Given this list of marker genes BHLHE40, SPPL2A, SNX25, NEUROG2, PTPRE, HOXB3, SP4, POU3F2, UBB, FAM120A, SF3B1, TPD52, ADGRL3, PCDH9, MIDEAS, EIF4A2, FBXO21, SRSF5, ATP6V1A, PLEKHA5, VCPIP1, GABRB3, PANK3, H3-3B, SUV39H2, B3GNT5, SLC30A8, EDNRB, GAPVD1, SH3D19, ARID1B, VEZT, OTX2, DDX3Y, ACACA, MAF, GPHN, FCHO2, PTP4A2, WDTC1, SNAP91, CSMD3, CYFIP2, PTPN3 (protein tyrosine phosphatase non-receptor type 3), SENP6, FOXG1, USP15, PCSK6, GGNBP2, SALL3, EPC2, SPTY2D1, PHF14, BMP2 (NCBI Gene Id 650), KANSL2, LRCH2, ACBD3, MEIS2, PPARA, UNC5D, TBL1X, DMRT2, KHDRBS2, STRN, ARL4A, FMN2, ZCCHC24, GAD1, FKBP4, FXR1, PCF11, GOLPH3, HNRNPH1, VPS8 (NCBI Gene Id 23355), UBR3, CHD6, CSNK1D, KIF4A, ATP10A, MATR3, MAPRE1, ZBTB18, ADCY1, MTMR6, ANKRD12, DCAF7, PPARGC1A, H3-5, ATP6V1B2, ST6GALNAC3, DLX1, RNF6, KLHL24, TNRC6B, GID4, SON, AMMECR1, IL13RA1, CAND1, KLHDC10, PPP2R5E, SBF2, VEZF1, MAGI1, METAP1, HNRNPA2B1, ZIC3, GPC4, NFIX, GABPA, PPP1R12A, GABRA2, RAB14, PARP1, UBQLN1, GPRASP2, MAK, SMAD4, FBXO33 (F-box protein 33), LUC7L3, TBR1, R3HCC1L, HOXA13, SRSF2, FAM117A, SOX3, SAMD8, FOXP1, PHACTR2, SPRY1, SPCS2, CPEB2, ARK2N, PPP3R1 (NCBI Gene Id 5534), LCA5, TOB1, ABR, RNF13, NRP2, DAZAP1, KCTD8, CREM, IMMT, NFAT5, ZFP36L1, ZNF319, ZFPM2, PPA2, KHDRBS3, ASF1A, TEAD1, NPY2R, USP33, SLC35A1, KMT2E, PHF20L1 (NCBI Gene Id 84165), CBLN2, PCBP1, RAP1B, ACVR1, RTL4, B4GALT5, SIPA1L2, PDS5A, LATS1, MRFAP1, NRIP1, CYRIA, TTC7B (NCBI Gene Id 145567), EHD3 (NCBI Gene Id 30845), LRATD2, FOXA1, PLPPR5, ADD3, CGGBP1, EIF3J, DNAJB6 (NCBI Gene Id 9186), MYT1 (myelin transcription factor 1), CDK19, SOX11, RAB7A, SPOP, DDX3X, USP1, RBM39, FZD4 (frizzled class receptor 4), SSX2IP, IRS2, BTBD3, TMEM243, ATP2C1, NFYB, PPP2R2C, LIFR, CCNT2, PAK5, RNF11, WNT3, FBXL3 (NCBI Gene Id 26224), RNF138, NHSL2, NUMB, CADM2, HORMAD1, PPP5C, CMSS1, MED13, DACH1, CREB5, UBE2V2, NUP153, GARRE1, YY1, DAAM1, TNFSF11, TLL1, HBEGF, DLEU7, ZMYND19, UBA2, C1QTNF7, ZBTB4 (NCBI Gene Id 57659), CREBZF, RHEB (Ras homolog, mTORC1 binding), MINDY3, INTS2, BCL11A, OSM, TMEM33, MYO1B, AZIN1, HDHD2, ZMIZ1, MBNL1, RAI1, FMR1, PDE4D, NR3C2, CTNND2, SIRT1 (NCBI Gene Id 23411), LRRTM4, BTAF1, FGFR2, here is a description of the gene set: Human Gene Set: ATGTTAA_MIR302C species: Homo sapiens Genes having at least one occurence of the motif ATGTTAA in their 3' untranslated region. The motif represents putative target (that is, seed match) of human mature miRNA hsa-miR-302c* (v7.1 miRBase).